Given this list of marker genes Ddr2, Fgf9, Tpm1, Adamts1 (ADAM metallopeptidase with thrombospondin type 1 motif 1), Ssh1, Myo5a, Drd4, Nox1, Lrp1, Adipoq, Rhoa, Smo, Prkg1, Dock7, Myh9, Dock5, Map3k7, Igfbp5, Gna12, Mef2c, Nrp1, Pak1, Xbp1, Ptpn1, Tert, Nr4a3, Nfe2l2, Mdm2, Agt, Gna13, Dock4, Atp7a, Myocd, Fat1 (NCBI Gene Id 76752), Pcsk5, Tafa5, Iqgap1, Nf1, Pdgfb, here is a description of the gene set: Mouse Gene Set: GOBP_REGULATION_OF_VASCULAR_ASSOCIATED_SMOOTH_MUSCLE_CELL_MIGRATION Any process that modulates the frequency, rate or extent of vascular associated smooth muscle cell migration. species: Mus musculus